Given this list of marker genes NPLOC4, THOP1, GAL3ST1, CEP68, CNNM3, INO80D, NEU3, POC1B, PROSER3, IFIT1, FAM120C, SH2B1, RPS26, ICAM4, PRDM10, PIAS3, DHH, HOOK2, ADAM1B, BRD4, ARL8A, RIN3, CLPP, VAMP2, EXTL3, HNF1A, DUSP10, KDM7A, CECR2, CCDC107, P4HTM, CEP57, AR, GNMT, RASGRP4, PROX2, ENOPH1, TAF8, WASF2, SCNM1, SCMH1, IRF2, LY96, EGR1, RBMS2, FAM117B, MBD6, TMEM150A, BANK1, MEF2D, AFF1, ZMYND10, AMDHD2, SLCO3A1, NSRP1, CD27, ANGPTL2, SH3BGRL3, PARD6G, RANBP10 (NCBI Gene Id 57610), SYT11, RFX7, ABCB9, EGR4, FBRS, TRAM2, EVI5L, POMT2, IFT20, TAF6, PYCARD, ERCC8, HIPK2, EPHB1, CRTC2, UROS (NCBI Gene Id 7390), CTDSPL, IKZF5 (IKAROS family zinc finger 5), LYSMD4, MAP3K11, MXRA7, WIPF2, GHDC, SETD1A, GRINA (glutamate ionotropic receptor NMDA type subunit associated protein 1), ULK3, MAPK1IP1L, DCP1A, POLR2L, NAGA, AP3D1, MAN2B2, CAMTA2, OLR1, PRODH2, GRK1, KRT73, CES2, ATXN7L1 (ataxin 7 like 1), PLEKHA7, NABP2, HELZ, AHSG, GYPC, TMEM170A, AMER3, ARID1B, RERE, CSF3R, AHR, TLR7, PRTN3, RASSF2, NEPNP, NMNAT1, CRTAM, BICRA, GPSM3, PACS1, HRH3, ANXA1, PRCP (NCBI Gene Id 5547), DAB2IP, ZBTB40, LENG9, PATL1, POU2F2, BUD13, TTLL9, MIR130A, SP2, PCDH20, IDUA, ITPRID2, USP21, KDM6B, PTPN13, SELENOP, UST, TOM1L2, IL6R, NUP35, TET1, MAF, OGFOD1, DLG4, TGM7, CDK16, CRTC3, GARIN5A, GATAD2B, PDE6B, MVB12B, EIF1AD, CDH2, here is a description of the gene set: from publication Cipolletta D, Feuerer M, Li A, Kamei N, Lee J, Shoelson SE, Benoist C, Mathis D (PMID 22722857) Human Gene Set: GSE37532_VISCERAL_ADIPOSE_TISSUE_VS_LN_DERIVED_TREG_CD4_TCELL_DN We identified Pparg as a major orchestrator of the phenotype of adipose-tissue resident regulatory T cells (VAT Tregs). To establish the role of Pparg in shaping the VAT Tregs gene profile and cell dynamics, Tregs from lymph nodes and visceral adipose tissue of mice sufficient and deficient of Pparg expression in Tregs were double sorted for microarray analysis. species: Homo sapiens Genes down-regulated in T reg of aged mice: visceral adipose tissue versus lymph node.